Given this list of marker genes PLCB1, ZSWIM2, UBE2K, CYREN (cell cycle regulator of NHEJ), ALDH3A2, MCTS1, LRCH2, MAP2, KLHL9, FOLH1B, EIF5A2, TMEM209, PAPOLA, IRAK3, SAP18, APC, SPRY1, COL21A1, PCDH18, OTUD4, RPS6KA6, CXADR, CLCN3, GET1, HERPUD2, SRSF1, DCK, CD24, NAA50, COL19A1, SMG1, ZNF143 (zinc finger protein 143), DYRK1A, THADA, FGFR1OP2, SOCS6, ANKRA2, CNTNAP4, TMEM68, REEP1, GPBP1L1, PTGER3, MAP3K20, HSD17B12, MCM2, FGFBP3, CPLX1, ZNF608, C17orf100, PDE4D, ZSCAN4, NUFIP2, ANKRD30B, CFAP52, HDLBP, FCHSD2, KLF12, PPP2R2C (NCBI Gene Id 5522), EDRF1, TMEM26, BBS10, ARFGEF1, SP4 (NCBI Gene Id 6671), CADM2, HSF2BP, CCDC9B, MFSD8, HSP90B1, PSMC6, MCM3, NKIRAS1, TRPS1, ARPC5, ZNF326, KIAA1328, JPH1, SLC6A11, NCS1, TMEM108, WDR20, PJA2, ANKRD20A2P, SPATA22, C2CD5, ELMOD1, FRMD3, NXPE3, SYF2, USP7, RBBP6, RCC2, UBE2Q2, NAGPA, RABGAP1L, REL, ACYP2, ANKRD20A1, PRICKLE2, PNO1, SP3, CDIN1, NRG1, SEMA5A, MBTPS2, TRPM7, NAA30, PPP3R1, REPS2, MRPS18C, C5orf15, AAK1, EFHC2, TOR1AIP2, LHX2, SMAD2, SUMO1, KIAA1958, RPS6KB1, STRN3, LARP1B, TP53BP1, SSH2, TRIM38, FOLH1, RAB5IF, ZC3HAV1, RFX7, ZNF48, TAF5L, ETNK1, SYAP1, HIVEP1, PURG, ANKRD20A4P, AFF4, CENPQ, TLR4, ZNF26, CPEB2, DEK, ANKRD20A3P, SEC16A, KMO, CMPK1 (cytidine/uridine monophosphate kinase 1), C3AR1, TMEM181, CAMK2D, PRRG4, CYP20A1, ZNF652, MAP1LC3B, BTF3L4, VDAC1, LRRC40, ZEB1, PSAT1, CHRNB1, HYCC1, TAF5, PGAP1, ATP6V0A1, ORC4, EPHA4, CEP83, ZNF639, WDR26, CDK13, ULK2, GSPT2, EFCAB11, EGLN3, PRELID2, NABP1, NAA16, JAG1, MOSPD3, MEP1A, ELAVL2, FUT9, RNPS1, MYH10, LIX1, EPHA7, FAM241A, ATAD2B, ZNF609, IL15, HLF, DENND4C, DCUN1D4, PYROXD1 (NCBI Gene Id 79912), TM9SF1, UQCRFS1, PRPSAP1, HAT1, ITGB8, CTAGE1, OLR1, IQGAP2, KIN, GATA3, CHMP4B, PRDM11, here is a description of the gene set: species: Homo sapiens from publication Chen Y, Wang X (PMID 31504780) Genes predicted to be targets of miRBase v22 microRNA hsa-miR-4272 in miRDB v6.0 with MirTarget v4 prediction scores > 80 (high confidence targets). Human Gene Set: MIR4272